Given this list of marker genes NUSAP1 (NCBI Gene Id 82534), GLA, GSN, SUOX, PDAP1, SLC7A9, WNT5A, BLVRA, BCL7A, IL10, MMD, RAB38, CCDC28A, RNH1, ANKRD36, MCUR1, ZMIZ1, TUBA1C, WDR83OS, AHNAK, MCCC1, BLVRB, CD1A, SYNGR2, ADCY9, PHYHIP, MLEC, BCAP31, GATM, CYREN, NFIL3, TSPAN4, BABAM2, PLEKHO2 (pleckstrin homology domain containing O2), PTGS1, TUBA1B, FN1 (NCBI Gene Id 2335), PGPEP1, C2CD2, IMMT, MSRA, COL15A1, NSF, FLT3 (NCBI Gene Id 2322), EHD4, TOR3A, ACADVL, ARRB1, DPP4, NR4A3, HLA-DQA1, TDRKH, TMT1A, FARP1, KRT5, GSE1, PPFIBP2 (PPFIA binding protein 2), HAO2, CCL24, MAF, PMFBP1, CAT, RASSF2, MAOA, PITRM1, TACR3, ALOX15B, CLIC2, ASAP1, CHN1, LMBR1L, CD1C, TM9SF1, SNRNP25, UQCRC1, PBOV1, SPINT2, GDF10, CYP51A1, TGFA, RFTN1, STK32B, AHCY, LSP1, QSOX1, PEX5L, TRAM2, CALU, FIBP, ANKRD26, CCL22, MCC, EBI3, CSF2RA (NCBI Gene Id 8282), ILVBL, CD226, TGM2, CHST15, HILPDA, DAG1, HGSNAT, EVI5, CD84, FCER2, SLC47A1, TGFBI, BCL11A, STARD3, ADIPOR1, SDC2, LMNA, OBSL1, APMAP, SFN, GNS (glucosamine (N-acetyl)-6-sulfatase), TBC1D9B, HTT, PLXDC1, MYT1L, HAGH, TINAGL1, RNF125, PYGL, C3orf18, TK2 (NCBI Gene Id 7084), LINC00837 (long intergenic non-protein coding RNA 837), SDF4, RXRA, EPB41L2, PDXK, DLGAP2, LHX2, DHRS1, BEX4, AP2A2, PPP1R3A, LGALS1, RAMP1, LAMP2, MAN2B1, LIPA, APLP2, WNT5B, FADS1, FETUB, ALOX15, IL1R1, CNIH3, GUSB, CCL17, FIG4, OMG, SMAD1, GAB2 (GRB2 associated binding protein 2), PLXNA2, DYRK4, MC5R, IL1RN, QPRT, GAS6, ANXA1, RHOBTB1, OCEL1, ENSG00000291006, NPC2, STMN1, AUH, GOLM1, DACT1, RNASE1, DIPK1A, MEA1, S100B (NCBI Gene Id 6285), HIVEP3, CD83, IRF4 (NCBI Gene Id 4592), CHST4, NFKBIE, HS3ST2, ADORA3, DNASE1L1, VDR, CCL18 (NCBI Gene Id 6362), MAL, PI4K2A, NAGA, PLA2G15, CREM, RNF5, BLTP2, IL1R2, TRIM15, SLAMF1, SPRY4, JAG1, CLEC10A (C-type lectin domain containing 10A), EMC3, SQLE, HRH1, KLF11 (NCBI Gene Id 8462), here is a description of the gene set: from publication Prots I, Skapenko A, Lipsky PE, Schulze-Koops H (PMID 21347372) species: Homo sapiens CD25+ regulatory T cells develop in the thymus (nTregs), but may also be generated in the periphery upon stimulation of naive CD4 T cells under appropriate conditions (iTregs). The mechanisms that regulate the generation of peripheral iTregs are largely unknown. We used microarrays to gain insights into the molecular program of extrathymic Treg development. Genes up-regulated in comparison of CD25- T cells treated with IL4 at day 3 versus untreated CD25- T cells at day 3. Human Gene Set: GSE24634_IL4_VS_CTRL_TREATED_NAIVE_CD4_TCELL_DAY3_UP